The following is a description of a gene set: Transcriptional regulation by the AP-2 (TFAP2) family of transcription factors studied in species Mus musculus Mouse Gene Set: REACTOME_TRANSCRIPTIONAL_REGULATION_BY_THE_AP_2_TFAP2_FAMILY_OF_TRANSCRIPTION_FACTORS, and this is the list of marker genes: Tfap2d, Kctd1, Tfap2a, Dek, Kdm5b, Cited2, Ep300, Sumo1, Tfap2b, Atad2, Npm1, Wwox, Esr1, Cited4, Lhb, Tfap2e, Myc (myelocytomatosis oncogene), Cga, Yeats4, Ube2i, Tfap2c, Cited1